The following is a description of a gene set: Human Gene Set: WP_SEROTONIN_AND_ANXIETY Serotonin and anxiety studied in species Homo sapiens, and this is the list of marker genes: HTR2A, TRPV1, FMR1, CAMK2B, PLEK, EEF2K, ARC, POMC, PPP3CA, ADRA1A (NCBI Gene Id 148), PRKCB, CRH, GABRA1, GRM1, PLCD4, HTR2C, FOS, HTR1A